Given this list of marker genes Hey1, Gja5, Smad4, Gata4, Dchs1, Efna1, Zfpm2, Tbx20, Twist1, Olfm1, Hey2, Sox9, Rhoa, Zfpm1, Notch1, Scx, here is a description of the gene set: Mouse Gene Set: GOBP_HEART_VALVE_FORMATION studied in species Mus musculus The developmental process pertaining to the initial formation of a heart valve from unspecified parts. This process begins with the specific processes that contribute to the appearance of the discrete structure and ends when the structural rudiment is recognizable.